The following is a description of a gene set: species: Homo sapiens The process of removing sections of the primary RNA transcript to remove sequences not present in the mature form of the RNA and joining the remaining sections to form the mature form of the RNA. Human Gene Set: GOBP_RNA_SPLICING, and this is the list of marker genes: MAGOH, DHX40, CIR1, PDCD7, PRMT7, RBM20, PRPF38B, TXNL4A, SNRPB2, RNU4-2, RBM25, GEMIN5, CLK1, CLASRP, ZC3H14, TIA1, NSRP1, DNAJC17, NCBP1, HOXB-AS3, SRSF8, PRDX6, HNRNPA1, ZC3H13, PPIL2, RBMX, RTCB, PPIG, RPS13, DDX42, RNU11, PAXBP1, RRAGC, RRP1B, PABPC1, SREK1IP1, PUS7 (pseudouridine synthase 7), WTAP, RNU4ATAC, PIK3R1, RPS26, USP22, RBM4, CWC15, SRRM1, FBXO24, ZRSR2, TGS1, ARMC7, RNVU1-17, SYF2, RBMY1D, RNF113A, DDX1 (NCBI Gene Id 1653), AQR, RTRAF, NCBP2, BRDT, PRKRIP1, MPHOSPH10, SF1, SDE2 (NCBI Gene Id 163859), FAM98A, AHNAK2, PRPF18, RNVU1-15, CCNL2, DHX9, CCNL1, SFPQ, THOC3, SCAF1, RBMXL3, RBMY1F, SNRPB, PRPF31, RNU6ATAC, SRPK1, HNRNPU, RNVU1-8, PRPF8, PRMT1, YJU2, CELF3, ERN1, RBFOX1 (RNA binding fox-1 homolog 1), RNU4-1, SF3B3, PRPF39, SRRM2, TAF15, CLP1, THOC5, TARDBP, UPF1, LUC7L2, SGF29, TCERG1, DDX39A, CELF5, SRSF7, RBM12, ZRSR2P1, LSM10, SLC38A2, SLC39A5 (solute carrier family 39 member 5), SF3A3, TSEN15, NPM1, RNU6-9, PRPF40A, GPATCH8, MBNL2, DHX16, RNU5E-1, LUC7L, RBM4B (NCBI Gene Id 83759), VIRMA, CRNKL1, THRAP3, PRPF38A, C1QBP, RBM17, RBM6, CENATAC (centrosomal AT-AC splicing factor), CLK4, BCAS2, THUMPD2, TADA2B, KAT2A, GPKOW, DDX20, DHX38, RNVU1-14, PLRG1, RNVU1-4, WDR77, GCFC2, HMX2, WT1, SNU13, ECD, AAR2, SNRPD1, TTF2, ESRP1, ESRP2, CWF19L1, RNU5F-1, CWC22, AKAP17A (A-kinase anchoring protein 17A), YJU2B, U2AF2, LSM1, RP9, ZCRB1, ARL6IP4, HNRNPUL2, KHDC4, SCNM1, LSM3, SNRPE, SRRM4, LSM4, DDX23, C9orf78, ZRANB2, RBM15, FRA10AC1, SNIP1, NCBP2L, LSM6, SRSF10, PUF60, HNRNPL, TRPT1, NUP98, RNU6-7, SF3A1, SNRPGP15, SNRPC, ELAVL4, RBM41, REST, HSPA8, SREK1, TRA2A, SRPK2, PPWD1, DCPS, CACTIN, HNRNPR, SF3B1, CLK3, KHDRBS2, KHDRBS3, PPP1R9B, RBM24, ILDR2, PSIP1, SLU7, IWS1, PRPF3, SNRNP27, SMNDC1, SF3B2, HNRNPH3, ZBTB7A, CDC5L, LSM7, AKAP8L, ILF3, PQBP1, PRPF19, TSEN54, LSM2, TAF10, MBNL1, ILDR1, RBMX2, THOC1, CDK13, PHF5A (NCBI Gene Id 84844), UBL5, HTATSF1, RBMY1J, METTL16, TAF5L, U2AF1, RNVU1-2A, SNRNP25 (NCBI Gene Id 79622), RBFOX2, QKI, RNU2-1, RBM7, LSM5, ZNF830, YBX1, DDX47, RPUSD4, PRPF4, DHX35, PTBP2, HNRNPH1, SNRNP35, PRX, C2orf49, SF3B5, SNRNP40, CWF19L2, TAF6L, MFAP1, RBM28, ZMAT5, PPIL3, SAP18, DDX39B, RBM42, RBPMS, TAF9, KHDRBS1, GEMIN2, UPF3B, DDX5, RBM10, GEMIN8, SMN2, PPIH, RNU5B-1, SRSF12, SCAF11, SNRNP48, HNRNPA2B1, TSEN2, CELF6, TADA3, TMBIM6, ARVCF, RNU1-4, RBM47, SART3, SNRPG, STRAP, USP4, USP39, TSSC4, USB1, SNRNP70, RALY, SUPT3H, TFIP11, LSM8, KAT2B, DDX41, ARGLU1, SRSF9, PRPF40B, HNRNPLL, SFSWAP, SNRPA1, SUPT6H, PRP4K, COIL, SNRPD3, SNRPA, GEMIN4, CTNNBL1, RSRC1, METTL3, SMN1, HNRNPK, HNRNPA3, RBM15B, DBR1, TRA2B, CDK11A, WBP11, PTBP3, BUD31, NOVA1, SRSF11, SART1, CDK11B, IVNS1ABP, METTL14, SRSF1, MYOD1, ZPR1, CLK2, RBMXL2 (RBMX like 2), RBM44, TRRAP, MAGOHB, ZMAT2, CELF1, UPF3A, YTHDC1, DYRK1A, RBMY1A1, CELF2, FAM50A, ALYREF, BUD13, HABP4, RBMY1E, PCBP4, SRSF6, FMR1, KHSRP, THOC7, RBM39, UMOD, RBM23, SRSF3, RBM38, CASC3, TAF12-DT (TAF12 divergent transcript), CWC27, NOVA2, CCAR2, SNRPF, RBFOX3, SNRPN, SRSF5, DAZAP1, CELF4, RBMXL1, HNRNPH2, THOC2, ZBTB8OS, SUPT7L, STH, AFF2, NRDE2, SYNCRIP, RBPMS2, WDR83, ISY1, RBM11, RBM48, SNRPD2, USP49, RBM5, SRSF2, RBMY1B, RBM14, MTREX, RNVU1-6, CDC40, THOC6 (NCBI Gene Id 79228), PRMT5 (protein arginine methyltransferase 5), HNRNPC, FUS, DDX46, RNPS1, RNPC3, LARP7, FAM98B, CIRBP, CLNS1A, ATXN7, HSPA1A, SMU1, HNRNPA1L3, ZC3H10, METTL4, RBM12B, SF3B6, PNN (NCBI Gene Id 5411), SF3A2, CRIPT, RBM22, SNW1, WEE2-AS1, CDK12, EXOSC10, RNU5D-1, NCL, SRPK3, PPIE, GEMIN7, SUGP1, SNRNP200 (NCBI Gene Id 692221), SON, SF3B4, ACIN1, HNRNPM, RNF113B, ZNF326, ZNF638, DHX15, EFTUD2, RSRP1 (NCBI Gene Id 57040), HNRNPUL1, LGALS3, U2AF1L4, POLR2A, PPIL1, RNU6-1, RBM3, SUPT20H, ENY2, PRPF6, JMJD6 (NCBI Gene Id 23210), SETX (NCBI Gene Id 85506), RBM8A, DDX17, ZCCHC8, HNRNPF, RNVU1-3, RNU5A-1, ATXN7L3 (ataxin 7 like 3), EIF4A3, SRSF4, XAB2, RNVU1-1 (NCBI Gene Id 26856), SUGP2, PPARGC1A, MBNL3, PTBP1, ARB2A, TSEN34, PPP4R2, AHNAK, GPATCH1, LUC7L3, PPP1R8, NONO, ESS2, GEMIN6, RNVU1-7, DHX8, CD2BP2, TADA1, WBP4, FRG1, TXNL4B, NOL3, IK, PUS1, HNRNPA1L2, CWC25, RNVU1-19, TAF12, GRSF1 (G-rich RNA sequence binding factor 1), INTS15, FASTK